The following is a description of a gene set: Any process that stops, prevents, or reduces the frequency, rate or extent of the controlled release of a substance from a cell or a tissue. species: Mus musculus Mouse Gene Set: GOBP_NEGATIVE_REGULATION_OF_SECRETION, and this is the list of marker genes: Gnao1, Spx, Chga, Rab11fip3, Nrg1, Kcnb1, Smcr8, Stxbp3, Ceacam1, Trim9, Acsl4, Trh, Maob, Asic1, Hmgcr, Midn, Syt4, Adora1, Cyp51, Mup1, Srcin1, Wnk4, Ada, Madd, Il6, Htr6, Klf7, Syt11, Ghsr, Crhr2, Pfkl, Notch1, Pde1c, Adtrp, Pparg, Il11, Ptger3, Cd200, Mup3, Uts2, Ins1, Nckap1l, Npy2r, Prkg1, Pim3, Il1b, Gpr39, Ppp3ca, Grm7 (glutamate receptor, metabotropic 7), Wdr41, Erbb3, Pla2r1, Eny2, Il12b, Mup11, Abr (active BCR-related gene), Il13ra2, Dph3, Fmr1, Pde3b, Gck, Cd84, Rsad2, Hadh, Fam3d, Rap1b, Crhbp, Vamp8, Jagn1, Ucn, Entpd1, Foxf1, Myo5a, Crhr1, Cartpt, Cry1, Sirt4, Drd2, Lep (NCBI Gene Id 16846), P2ry1, Npy5r, Vamp3, Inhbb, F2rl1 (F2R like trypsin receptor 1, NCBI Gene Id 14063), C9orf72, Npff, Ptpn11, Ucn2, Pou5f1, Htr7, Npy1r, Idua (iduronidase, alpha-L, NCBI Gene Id 269679), Tspo, Nmb, Edn1, Tnfrsf1b, Egf (NCBI Gene Id 99717), Lif, Rhbdf2, Rhbdf1, Rab11fip5, Vps4b (NCBI Gene Id 319619), Tbc1d1, Tifab, Wnk1, Ucp2, Rab7, Drd3, Igfbp3, Gnaz, P2ry12, Gabbr1, Oprk1, Idh2 (NCBI Gene Id 269951), Kcnk9, Foxo1, Pde8b, Tcp11, Nucb2, Bcr, Agtr2, Adipoq, Ptprv, Atp9a, Ppp1r9a, Cry2, Cd74, Kcnq1 (potassium voltage-gated channel, subfamily Q, member 1), Ins2, Frmd4a, Sirt1, Edn3, Htr1b, Mup4, Ccr2, Npvf, Ptger4, Nr1h3, Acvr1c, Psmd9 (NCBI Gene Id 74214), Prkn, Crh, Npsr1, Hrh2, Fgf23, Inha, Ffar3, Rab11fip1, Pde4c, Irs1, Rap1a, Htr1a, Fbn1, Ccn3 (NCBI Gene Id 18133), Kalrn, Tacr2, Kcnj11, Oprm1 (NCBI Gene Id 18390), Apoe, Lgals9, Osm, Ghrl, Stk39, Rab33b, Gnai2, Ggcx, Ffar2 (NCBI Gene Id 233079), Tnf, Snca, Abcc8, Ptpmt1, Braf, F2r, Neo1, Spi1, Tff2, Sfrp1, Ndufaf2, Sergef, Ffar4, Rabgef1, Hmox1, Map4k4, Rptor, Anxa1, Anxa5, Adra2a, Atp5pf, Edn2, Mup2, Nf1, Kcnj6, Gnai1, Drd4, Stxbp5l, Srebf1, Pnkd, Tnfrsf1a, Wnk3, Nmu, Mup5, Cnr1, Mtnr1b, Cd300a, Cbarp, Rest, Sct, Hrh3, Slc30a1, Il1rapl1, Nos1, Il1rn (interleukin 1 receptor antagonist), Ptgs1, Erp29, Gja1, Fkbp1b, Il12a, Vsnl1, Ifnb1, Mtnr1a, Neurog1, Sytl4 (synaptotagmin-like 4), Abat